The following is a description of a gene set: Hyperoxaluria Increased excretion of oxalates in the urine. studied in species Homo sapiens Human Gene Set: HP_HYPEROXALURIA, and this is the list of marker genes: AGXT, OXGR1, HOGA1, PEX1, GRHPR, SLC26A1